Given this list of marker genes NDUFS7, DNAJC25, SMG8, MTCO3P12, DYNC2I1, LINC01775, MRNIP, SF3A3, PSPN, LRRC37A5P, FBLIM1, WDR11, RN7SKP150, CCDC180, TMEM242-DT, DRG2, UBXN4, MTND5P11, MROH1, RPL18P10, SSBP1, PPP4R1L, DNAJC25-GNG10, AURKAIP1, FANCA, SLC24A1, RAB5CP1, VPS51, CDKN2A, FAM230G, RPL30P3, WDR11-DT, TMEM242, E2F2, WEE2-AS1, SNX14, COX16, ZNF746, CARD8 (caspase recruitment domain family member 8), MRPS31P5 (NCBI Gene Id 100887750), INTS14, PRSS16, JPX, here is a description of the gene set: species: Homo sapiens Genes containing one or more binding sites for (ZFP82) in their promoter regions (TSS -1000,+100 bp) as identified by GTRD version 20.06 ChIP-seq harmonization. Human Gene Set: ZFP82_TARGET_GENES from publication Yevshin I, Sharipov R, Kolmykov S, Kondrakhin Y, Kolpakov F (PMID 30445619)